The following is a description of a gene set: studied in species Homo sapiens Human Gene Set: REACTOME_RHO_GTPASES_ACTIVATE_IQGAPS RHO GTPases activate IQGAPs, and this is the list of marker genes: TUBA8, TUBA1B, TUBB4A (tubulin beta 4A class IVa), IQGAP3, TUBB2B, TUBB2A, TUBB6, IQGAP2, TUBAL3, CLIP1, CTNNB1, TUBB4B, TUBB3, ACTB, MEN1, TUBA1C, TUBB1, CTNNA1, TUBB8, TUBA1A, TUBA4A, TUBA3D, CALM1, IQGAP1, TUBB8B, CDC42, TUBA3E, RAC1, TUBA3C, ACTG1, TUBA4B, CDH1